The following is a description of a gene set: Binds to and increases the activity of a lipase, an enzyme that catalyzes of the hydrolysis of a lipid. Mouse Gene Set: GOMF_LIPASE_ACTIVATOR_ACTIVITY species: Mus musculus, and this is the list of marker genes: Arf1, Pdgfra, Arf4, Apoh, Gpihbp1, Plaa, Arl1, Abhd5 (abhydrolase domain containing 5), Nsmaf, Pdpk1, Stx4a, Src, Apoa5, Btk (NCBI Gene Id 215271), Gm2a, Hras, Apoc2, Ccl3, Ccl8, Eed, Ccl5, Arhgap6, Fyn, Apoc2l, Lck, Casp3